Given this list of marker genes RPS27A, EPS15, UBC (ubiquitin C), UBB, UBA52, GRB2, STAM2 (NCBI Gene Id 51453), SH3GL1, STAM, SH3GL2, HGS, MET, inlB, SH3KBP1, CBL, SH3GL3, here is a description of the gene set: InlB, a cell wall protein of Listeria monocytogenes, binds MET receptor, acting as an HGF agonist. Listeria monocytogenes InlB proteins dimerize through their leucine-rich repeat regions (LRRs), promoting dimerization of MET receptors that they are bound to. InlB-induced MET receptor dimerization is followed by MET trans-autophosphorylation and activation of downstream RAS/RAF/MAPK signaling and PI3K/AKT signaling. InlB-bound phosphorylated MET receptor recruits the E3 ubiquitin ligase CBL through GRB2. CBL-mediated monoubiquitination of InlB-bound MET promotes endocytosis and entry of Listeria monocytogenes to host cells. CIN85 is necessary for endocytosis-mediated entry of Listeria monocytogenes triggered by CBL-mediated monoubiquitination of MET. Proteins involved in clathrin-mediated endocytosis EPS15 and HGS (Hrs) are both necessary for CBL and MET-mediated entry of Listeria monocytogenes into host cells.<br>A potential coreceptor role of CD44 in InlB-mediated MET activation is contradictory. part of: Listeria monocytogenes entry into host cells Reactome Pathway: InlB-mediated entry of Listeria monocytogenes into host cell studied in species Homo sapiens